Given this list of marker genes COG1, GALE, CD36, PTPRJ, ITGA2B, ACTN1, ANKRD26, GATA1, MYH9, PRKACG, GP9, ABCG8, TPM4, FYB1, TUBA8, GNE, SKIC3 (SKI3 subunit of superkiller complex), SLC35A1 (NCBI Gene Id 10559), GP1BB (NCBI Gene Id 89199), GP1BA, ARPC1B, ABCG5, ITGB3, TUBB1, LBR, WAS, FLI1 (Fli-1 proto-oncogene, ETS transcription factor), FLNA, DIAPH1, CYCS, ACTB, CDC42, SKIC2, GFI1B, here is a description of the gene set: Human Gene Set: HP_ABNORMAL_PLATELET_VOLUME species: Homo sapiens Abnormal platelet volume Anomalous size of platelets. Most normal sized platelets are 1.5 to 3 micrometers in diameter. Large platelets are 4 to 7 micrometers. Giant platelets are larger than 7 micrometers and usually 10 to 20 micrometers.